Given this list of marker genes TDRKH, MAGED1, ZMIZ2, HNRNPD, ZNF266, WEE1, NDRG1, GPAT4, SLC16A6, GPSM1, FBRS, RUNDC3A, AARS1, CD83, STRIP2, MGAT5, GINS1, SLC19A2 (NCBI Gene Id 7826), RFC2, CD81, LIMK1, RAB8B, PEBP1, C1QTNF12, SLC9B2, MFSD4A (major facilitator superfamily domain containing 4A), RANBP1, PELP1, ZNF839, TBL3, DDX39A, UNC119, RB1, LYAR, PHGDH, GSPT1, UBE2E3, SSBP1, AHCYL2, DHX58, IFT122, KIT, N4BP2, HEMK1, ALDH2, BCL2L13, LMF1, PHB2, SLC5A6, NDC1, MTHFD2L, YPEL2, PTGIR, ITIH5, TBC1D4, LITAF, PLOD2, SPIN4, MAD2L1, CSNK1D, MSH6, SNX18, NUTF2, UPF3B, UCK2, SYCE2, BCL3, PURG, MPHOSPH6 (M-phase phosphoprotein 6), PLEKHO1, HACD3, PREP, E2F3, ABL1, NAMPT, TGIF1, PLA2G12A, MAGOHB, MCUB, OAF, ADGRG3, STX11, TNFSF11, DGCR6, LAD1, AS3MT, ZMYM4, UBQLN4, SECTM1, NYAP1, SLC16A10, ACOT7, STK38L, KDM6B (lysine demethylase 6B), TRMT61A, GSAP, RPGR, CDC14A, VAV3, SELP, GLCCI1, RELB, SCNN1A, PSMD11, PDE7B, GPRASP3, HSPA13, FABP5, MCM5, ZNF467, RASL11B, FOSL2, ATP5IF1, PPP1R16B, IMPDH2, EZH2, CCDC88A, ABCD3, SREK1, CD200, SMO, MED23, TYW3, GNB1L, CAPRIN1, ZNF22, RCC2, FBXL19, RSPH3 (NCBI Gene Id 83861), PRKAB2, ZNF207, SRM, PPM1B, CHL1, FASN, VDAC1, RGS12, IL2RA, AFDN, SMYD2, RAI1, CUX1, PDCD5, TRAF4, ERGIC1, CTSW, NFYB, EEF2K, DENND6B, BMAL1, SMIM3, PIK3R3, CHSY1, LPIN2, AKR1C3, CENPW, AGBL5 (AGBL carboxypeptidase 5), GADD45B, AHI1, SLC7A1, PPA1, SLC12A2, SLC35B1, DCTD, EHMT1, ALDH7A1, STAT5A, CHEK1, METAP2, BEX1, RAPH1, DUSP5, CCT6A, EXT1, BCAT1, SMOX, CEP78, COLQ (NCBI Gene Id 8292), BCL2L1 (BCL2 like 1), PHACTR2, NT5C2, RBMXL1, ALAD, NLRX1, ASNS, GPS1, PARD6G, JDP2, AKAP1, MYH10, CKB, CD99L2, ZNHIT6, CHRNB1 (cholinergic receptor nicotinic beta 1 subunit), STX6, CAD, CPD, MYB (MYB proto-oncogene, transcription factor), CEP19, GREB1, here is a description of the gene set: species: Homo sapiens from publication Fu W, Ergun A, Lu T, Hill JA, Haxhinasto S, Fassett MS, Gazit R, Adoro S, Glimcher L, Chan S, Kastner P, Rossi D, Collins JJ, Mathis D, Benoist C (PMID 22961053) Genes down-regulated in CD4 T conv over-expressing GATA1 versus GATA1 and FOX3P. The transcription factor FoxP3 partakes dominantly in the specification and function of FoxP3+ CD4+ T regulatory cells (Tregs), but is neither strictly necessary nor sufficient to determine the characteristic Treg transcriptional signature. Computational network inference and experimental testing assessed the contribution of several other transcription factors (TFs). Enforced expression of Helios or Xbp1 elicited specific signatures, but Eos, Irf4, Satb1, Lef1 and Gata1 elicited exactly the same outcome, synergizing with FoxP3 to activate most of the Treg signature, including key TFs, and enhancing FoxP3 occupancy at its genomic targets. Conversely, the Treg signature was robust to inactivation of any single cofactor. A redundant genetic switch thus locks-in the Treg phenotype, a model which accounts for several aspects of Treg physiology, differentiation and stability. Human Gene Set: GSE40274_GATA1_VS_FOXP3_AND_GATA1_TRANSDUCED_ACTIVATED_CD4_TCELL_DN